The following is a description of a gene set: studied in species Mus musculus Mouse Gene Set: GOMF_FATTY_ACID_OMEGA_1_HYDROXYLASE_ACTIVITY Catalysis of the reaction: an (omega-1)-ethyl fatty acid + O2 + reduced = an (omega-1)-hydroxy fatty acid + H+ + H2O + oxidized., and this is the list of marker genes: Cyp2c29, Cyp2c50, Cyp2e1, Cyp2c39, Cyp2c38, Cyp4f13, Cyp2c37, Cyp1a1, Cyp4f18